Given this list of marker genes PLCG2, TGFBI, AHCYL2, UBTD1, FUCA1, ENG, HSD11B1, PLEKHM1, CDKN1A, FBXO21, LMO2, RGS14, DTX4, H2BC21, HLA-DOB, CCDC106, GCGR, RESF1, WDR37, PLEKHG3, RGS2, CTSZ, PDXDC1, SLCO3A1, SEL1L, SST, CEACAM5, LYL1, LILRA2, MSRB1, SESN1, CLN8, HLA-DQA1, DCSTAMP, BMAL1, TLE1, CYP27B1, CD36 (CD36 molecule (CD36 blood group)), MAN2B1, CHRNG, CREB5, TAL1, CD209, PITPNA, SPARC, SERPINA1, VCL, SOCS6, SORT1, PCSK5, HK3 (hexokinase 3), DUSP22, LITAF (lipopolysaccharide induced TNF factor), TH, ZNF623, TSC22D1, HLA-DQB2, PLXNA1, CPEB1, DAP, CPVL, MRC2, TLR2, CCL22, PTGS1, PLXND1, UBAP1, MIR622, PDE8A, HFE, RIOK3, ANXA1 (annexin A1), GUCA1A, CACNA2D3, C1orf115, FCGR2C, SLC2A9, FA2H, PDLIM4, SLC15A3, ACO2, FTH1P5, CKMT2, CLEC4A, THBD, ARMCX1, MITF, NFKBIE, ZNF750, NPPC, ECHDC3, BPI, TACSTD2, GPER1, SETD3, PILRA, CHST15, CLEC10A, EPCAM (NCBI Gene Id 4275), LRP10, ACOX2, TNFRSF21, BST1, KLHL24, CRYBG3, PEPD, TRIO, PSAP, ALCAM, BASP1, REX1BD, PTX3, ADM, PTK2, FZD5, ADCK2, NQO1, GASK1B, FAM204A, PHF1, ZNF768, FAM13C, FTH1, RAB9A (RAB9A, member RAS oncogene family), KDM7A, TMBIM1, PRM1, MTCL1, FAR2, CLEC11A, SSX7, LRRC8D, ABCG2, PRDX6, MRAS, TMCC1, RORC, DSC2, RENBP, ANXA2P1, CST3, ZKSCAN1, TRAF3, H2AC6, JUP, HLA-DRA, ATP6V1H, NLRP3, ENC1, ALOX15, CLCN7, MATK, GPD1, ULK2, CHI3L1, SLC48A1, RTN2, IFNAR2, ANPEP, SNX13, HECTD3, MAP1LC3B, SLC9A6, CD1D, PZP, C5AR1, ASPH, PYGL, LILRA5, TMEM87A, ASPHD1, SLC22A5, TNS1, EPS15L1, ARHGAP22, BID, CTSH, TPP1, CD83, MX2, PARM1, SCG3, CD33, SLC7A7, SCARB1, SEC14L5, COQ10B, SLAMF8, SMAD6, SLC31A2, ZNF223, PPP1R15A, DIAPH2, PGLYRP1, ZNF358, SEC23B, ROBO3, NSF, GYG1, GTF2IRD1, here is a description of the gene set: Human Gene Set: GSE3982_DC_VS_TH2_UP species: Homo sapiens from publication Jeffrey KL, Brummer T, Rolph MS, Liu SM, Callejas NA, Grumont RJ, Gillieron C, Mackay F, Grey S, Camps M, Rommel C, Gerondakis SD, Mackay CR (PMID 16474395) In the present study we used Affymetrix oligonucleotide microarrays to produce gene transcription profiles for the major leukocyte types in humans. This comprehensive dataset enabled us to not only establish which genes were expressed in each leukocyte type, but also which genes were expressed in each subset after activation. The used of a comprehensive dataset of gene profiles from all the major human leukocyte subsets enabled a novel and powerful means for identification of genes associated with single leukocyte subsets, or different immune paradigms. Genes up-regulated in comparison of dendritic cells (DC) versus Th2 cells.